Given this list of marker genes EBF3, SNRPN, IQSEC2, SPOP, ACTB, SETBP1, POLR3A, PLAAT3, SKI, KNSTRN, JARID2, HUWE1, NF1, DPH5, CILK1, CTCF (CCCTC-binding factor), TRIM8, NALCN, EP300, GATA4, NTRK1, ACBD6 (acyl-CoA binding domain containing 6), CRB1, SSR4, SIN3A, SHANK3, BCR, FARSA, ZC4H2, BBS7, AGL, RERE, HS6ST2, JAG1, CDKL5, SPIN4, GSC, TBCE, ERCC8, SH3PXD2B, CASZ1, ATAD3A, TRRAP, RAB3GAP2, FLII, EEF1A2, CREBBP, H3-3A, ERCC6, DLK1, SEPTIN9, SLC32A1, NEDD4L, SON, TBCD, POLR1A, RALGAPA1, IFT56, PRKDC, MAD1L1, TBX15, MYH3, RNF2, MAFB, ERCC1, NGF, TCF4, PRPS1, PAK1, RARS2, TOGARAM1, RAB3GAP1, WASF1, DPYSL5, OPHN1, CAMTA1, GORAB, CTBP1, PSMD12 (NCBI Gene Id 5718), CACNA1G, KDM5C, ASXL3, TPRKB, HNRNPC, FBXO31, HACE1, XRCC4, NAA10, GRIA3, SRCAP, POU4F1, BBS2, SLC9A6, SALL4, TPR, TBCK, PIK3R1, SATB2, PLEC, PLAA, FOXF1, BAP1, OCRL, MED12L, GNB2, SLC9A7 (NCBI Gene Id 84679), CAMK2B, STAT3, KIF7, TAF4, KIDINS220, ARNT2, ZPR1, PYCR1, KAT6A, PRDM16, MEG3, ZEB2, GABRD, DYRK1A, CHN1, AGO2, STIM1, COX5A, PPP2R5D, EMC1, PRMT7, SYNGAP1, MEIS2, RNU4-2, GATAD2B, PIGU, THOC6, EXTL3, KMT2E, PIK3CA, AHDC1, PHF6, ATN1, UGDH, H4C5 (H4 clustered histone 5), NFIX, HDAC4, SPEN, PIK3CD, UBE3A, DHPS, IGF1R, KCNK4, SRRM2, DIS3L2, TCF20, CARS1, CDH2, PRR12, ERCC4, OSGEP, TAF1, CRPPA, FBXO11, ORAI1, ZNF668, EIF5A, GJA8, RHOBTB2, DNA2, GPKOW, SETD1A, TMEM237, UBE4B, CENPF, PDPN, ASH1L, ODC1, SPTBN1, PDCD6IP (NCBI Gene Id 245794), GNS, ALMS1, GRIN1, PLP1, AP1S2, MYT1L, SUOX, KMT2B, ABL1, IARS2, TMEM94, TGFB2, CEP57, FARSB, SMC1A, GJA5, HSPG2 (NCBI Gene Id 7796), COL5A1, ERCC2, RTL1, PAK3, ANKRD17, SRC, MMP23B, FBN1, HDAC8, MIPEP, EDEM3, PUF60, UBE2A, POU1F1, PGAP1, EPB41L1, HYLS1, TBC1D20, ALKBH8, NDP, FMR1, TRIP13, EXOSC2, COX8A, CNOT3, CAPRIN1, DCPS, HHAT, WAC, TTI2 (NCBI Gene Id 80185), STAG1, SMAD4, LAS1L, GJA1, BPTF, BICRA, YARS1, LARP7, TAFAZZIN, ZBTB20, COA3, KCNAB2, GLYCTK, HMGA2, PIEZO2, LIFR, MAPK8IP3, MEF2C (NCBI Gene Id 4208), PRKCZ (protein kinase C zeta), IPO8, TBL1XR1, HECW2, RAI1, CRKL, DPYD, DNM1L, RECQL, PHIP, POC1A, MSL3, UBAP2L, COL3A1, DNAJC21, LEMD3, NOVA2, WDR26, BRCC3, TMEM67, DEAF1, SLC35A1, SCN4A, PIGY, FIBP, LUZP1, MAPK1, TRPM3 (NCBI Gene Id 80036), PUS7, here is a description of the gene set: Deeply set eye An eye that is more deeply recessed into the plane of the face than is typical. Human Gene Set: HP_DEEPLY_SET_EYE studied in species Homo sapiens